Given this list of marker genes GLS, GAD2, AKR7A2, GAD1, DPEP1, PON3, MAOB, ADHFE1, ABAT, ALDH5A1, GLS2, here is a description of the gene set: Human Gene Set: WP_GABA_METABOLISM_AKA_GHB studied in species Homo sapiens GABA metabolism (aka GHB)